Given this list of marker genes Xpc, Cetn2, Ino80e, Uba52, Nfrkb, Uba52rt, Ino80c, Cops8, Cops7b, Actl6a, Actr5, Parp1, Cops3, Ubc, Ino80b, Rad23a, Parp2, Yy1, Cops7a, Actr8, Ddb2, Cul4a, Cops2, Cul4b (NCBI Gene Id 72584), Actb, Ddb1, Tfpt, Cops5, Rbx1, Cops6, Gps1, Rps27a, Mcrs1, Ino80 (NCBI Gene Id 76476), Cops4, Ino80d, Ubb, Ruvbl1, Rad23b, here is a description of the gene set: DNA Damage Recognition in GG-NER Mouse Gene Set: REACTOME_DNA_DAMAGE_RECOGNITION_IN_GG_NER studied in species Mus musculus